Given this list of marker genes FCGR3B, CARD11, PLEKHF1, FASLG, TARP, PRKCH, here is a description of the gene set: RTS,S is an advanced malaria vaccine candidate and confers significant protection against <i>Plasmodium falciparum</i> infection in humans. Little is known about the molecular mechanisms driving vaccine immunity. Here, we applied a systems biology approach to study immune responses in subjects receiving three consecutive immunizations with RTS,S (RRR), or in those receiving two immunizations of RTS,S/AS01 following a primary immunization with adenovirus 35 (Ad35) (ARR) vector expressing circumsporozoite protein. Subsequent controlled human malaria challenge (CHMI) of the vaccinees with <i>Plasmodium</i>-infected mosquitoes, 3 wk after the final immunization, resulted in ~50% protection in both groups of vaccinees. Circumsporozoite protein (CSP)-specific antibody titers, prechallenge, were associated with protection in the RRR group. In contrast, ARR-induced lower antibody responses, and protection was associated with polyfunctional CD4<sup>+</sup> T-cell responses 2 wk after priming with Ad35. Molecular signatures of B and plasma cells detected in PBMCs were highly correlated with antibody titers prechallenge and protection in the RRR cohort. In contrast, early signatures of innate immunity and dendritic cell activation were highly associated with protection in the ARR cohort. For both vaccine regimens, natural killer (NK) cell signatures negatively correlated with and predicted protection. These results suggest that protective immunity against <i>P. falciparum</i> can be achieved via multiple mechanisms and highlight the utility of systems approaches in defining molecular correlates of protection to vaccination. from publication Kazmin D, Nakaya HI, Lee EK, Johnson MJ, van der Most R, van den Berg RA, Ballou WR, Jongert E, Wille-Reece U, Ockenhouse C, Aderem A, Zak DE, Sadoff J, Hendriks J, Wrammert J, Ahmed R, Pulendran B (PMID 28193898) Genes positively correlated with protection in peripheral blood mononuclear cell in unknown after exposure to P. falciparum RTS,S/AS01, time point 56D studied in species Homo sapiens Human Gene Set: KAZMIN_PBMC_P_FALCIPARUM_RTSS_AS01_AGE_UNKNOWN_CORRELATED_WITH_PROTECTION_56DY_POSITIVE